The following is a description of a gene set: Undetectable electroretinogram Lack of any response to stimulation upon electroretinography. Human Gene Set: HP_UNDETECTABLE_ELECTRORETINOGRAM species: Homo sapiens, and this is the list of marker genes: TULP1, CRX, FLVCR1, NRL, CLN3, MYO7A, CRB1, EYS, HSD17B4 (hydroxysteroid 17-beta dehydrogenase 4), USH1C, RPGRIP1, TPP1, NR2E3, PROM1, PCYT1A, NMNAT1, CLCC1, LRAT (lecithin retinol acyltransferase), PDE6D, RPE65, CLN8, PRCD, PPT1, SPATA7 (NCBI Gene Id 55812), LCA5, IFT140, CC2D2A, POMGNT1, KIZ